The following is a description of a gene set: from publication Chen Y, Wang X (PMID 31504780) Mouse Gene Set: MIR_6896_3P species: Mus musculus Genes predicted to be targets of miRBase v22 microRNA mmu_miR_6896_3p in miRDB v6.0 with MirTarget v4 prediction scores > 80 (high confidence targets)., and this is the list of marker genes: Septin6, Htr2c, Cdr2l, Cpeb4, Prrx1, Tmem169, Klhl29, Acsl6, Arl14ep, Satb1, Shox2, Ldb2, Skint3, Mbnl1, Usp48, Wnt3a, Zfp967, Dip2c, Vezt, Cog7, Jrkl, Dlx1, Txndc9, Zfp935, Ndufb11b, Ano3, Zfp808 (zinc finger protein 808), EU599041, Pou4f1, Ptpro, Timd2, Zfyve26, Me3, Adam12, Fktn, Fancl, Zfp931, Phlpp1, Ptprb, Cdh6 (cadherin 6), Dynlt5, Phactr1, Arf6, Synpr, Myt1, Bnc2, Mapre2, Cdon, Cadps2, Slc16a10, Zfp971, Snx5, Tob2, Dcx, Rab11fip3, Zfp975, Xkrx, Cd226, Ms4a1, Zfp955b, Ip6k1 (NCBI Gene Id 67601), Itga4, P3h1, Rhbdl3, Zfp937, Slc13a3, Rtn4rl1, Deptor, Irx5, Zfp229 (NCBI Gene Id 381067), Fgf12, Ltn1, Enc1, Anpep, P2ry10, Zfp729a (NCBI Gene Id 212281), Stat3, Sh3kbp1, Gm5141, Npr3, Cers4, Zfp462, E330034G19Rik, Zfp942, Zmiz1, Rest, Zfp655 (NCBI Gene Id 72611), Plxna2, Slit3, Zfp759, Pogz, Clec1b, Rex2, Zfp442, Zfp958, Gm14296, Palld, Brcc3, Acsl3, Gm2026, Zfp966, Egr3, Ptgfrn, Neurl1b, Rdh12 (NCBI Gene Id 77974), Edc3, Slc17a5, Gm14434, Zfp386, Zfp704, Kremen1, Ddr2, Socs7, Zfp980, Pigb, Tmtc2, Zfp869, Glp2r, Fam78a, Grm4, Srxn1, Trak2, Miga2, Rimklb, Zfp951 (zinc finger protein 951), Zfp976, Plxdc2, Onecut2, Rnf216, Tnfrsf11b, Il5ra, Gpr3, Thap12, P2ry6, Phf20l1, Zfp982, Gm14308, Nuak2, Hmx3, Zkscan8, Abhd10, Rbm46, Cstf3, Zfp936, Larp4, Mylk (myosin, light polypeptide kinase), Rab27b, Plxdc1, Slc12a6, Mxd1, Nudt10 (nudix hydrolase 10), Kazn, Man1a2, Camta1, Def8, Msl1, Vps37a, Ppp3r1, Socs2, Ccdc169, Zfp820, Pik3r1, Zfp973 (NCBI Gene Id 668009), Gm14391, Magi3, Cdcp1, Il7, Rc3h2, Ankrd10, Zfp1009, Rasgrf2, Elfn1 (NCBI Gene Id 243312), Unc80, Gm4841, Septin11, Map1b, Ccdc42, Cops6, Zmynd8, Map3k12, Gm14326, Hvcn1, Zfp36l1, Zfp65, Prkcb, Pcsk2, Gm6710, Zmat1, Zfp558, Pcdh17, Cpm, Zc3h7b, Atp2b1, Zfp960, Zfp629, Zfp433, Tnrc6b, Rsf1, Pdk4, Tef, Nhsl3, Etv6, Tbl1xr1, Ptgr3 (prostaglandin reductase 3), Chd5, Pmepa1, Ccdc126, Gm14322, Spop, Zfp979, Myocos, Magt1, Krit1, Mier3, Phc3, Gpc6 (NCBI Gene Id 77735), Septin8, Kcnj3, Sptssb, Zfp97, Zfp874b, Atp1a2, Cx3cr1, Zzz3, Tppp, Hivep3, Gdap1l1 (ganglioside-induced differentiation-associated protein 1-like 1), AU041133, Ipcef1, Sla2, Zfp600, Map2, Zfp781b, Zfp872, Pura, Zfp811, Fbxl3, Zfp120, Vmn1r45, Pik3c2a, Ubn2, Zfp87, Mtpn, Eda, Hivep2, Dkc1, Gm6712, Bltp3a, P2ry10b, Sbno1, Prkab2, Ror2, Pak3, Slc24a2, Frmpd4, Glis3, Mrpl36, Sema6d, Virma, Pdia6 (NCBI Gene Id 97794), Gm14325, Cebpg, Bhmt, Rslcan18, Bmp2k, Kif5a, Snx27, Gpatch2l, Zfp965 (NCBI Gene Id 100503949), Zfp970, Fam120a, Cdca7l, Tgfbr1, Entpd1, Cers6, Ccdc88a, Gsk3b, Gucy1a2, Unc5c, Rin2, Mbnl3, Necab1, Zfp37, Jade2, Zfp459 (NCBI Gene Id 328274), Nipal1, Creb5, Manea, Bace2, Kcmf1, Rbfox2, Ovol3, Zfp953, Tyw3, Zfp92, Zfp738, Zfp729b, Pcdh9, Arid3a, Sox1, Col11a2, Zc3h12a, Tbcel (NCBI Gene Id 78293), Slc7a11, Sgms1, Colq, Prdm13, Hdac9, Zfp930, Dgkd, 2210418O10Rik, Npl, Zfp981, Ppp1r1c, Slc8a3, Ubap2l, Gm4724, R3hdm1, Asph, Slain2 (NCBI Gene Id 75991), Tmem9, Plxna4, Gspt2, Gcsam, Stc1 (stanniocalcin 1), Kif3a, Tmem245, Gse1, Sike1, Zfp983, Cyria, Zfp955a, Pam, Zfp493, Cipc, BC037156, Sema3a, Ptpn14, Zfp1008, Ugcg, Csad, Pcgf3, Fut9, Lin28a, Isx, Sphkap, Zfp934, Slc9b2, Cisd2, Cpeb2 (cytoplasmic polyadenylation element binding protein 2), Rabgap1l